The following is a description of a gene set: Any process that results in a change in state or activity of a cell (in terms of movement, secretion, enzyme production, gene expression, etc.) as a result of an ultraviolet radiation (UV light) stimulus. Ultraviolet radiation is electromagnetic radiation with a wavelength in the range of 10 to 380 nanometers. studied in species Homo sapiens Human Gene Set: GOBP_CELLULAR_RESPONSE_TO_UV, and this is the list of marker genes: ERCC1, RBX1, ST20, MDM2, HYAL2 (NCBI Gene Id 8692), SMPD1, PTPRK, COPS9, POLH, MC1R (NCBI Gene Id 4157), TAF1, OPN3, INO80, BAK1, TP53INP1, OPN1SW, EIF2S1, POLD3, RUVBL2, TMEM161A (NCBI Gene Id 54929), MAPK11, CRIP1, PRKCD, OPN5, DDB1, BAX, CERS1, RPL26, KDM1A, EP300, TP53, ERCC4, FBXW7, PBK, PIERCE1, NOC2L, NLRP1, AURKB, XPA, RHBDD1, MAP3K20, POLD1, MME, SIRT1, POLA1, XPC, ACTR5, MMP2, PARP1, MAPK14, POLK, CREBBP, ATF4, N4BP1, USP28, CDKN1A, TRIAP1, MAPK13, RHNO1 (NCBI Gene Id 83695), ZBTB1, HYAL3, HYAL1, MFAP4, AQP1, CUL4B, METTL3, YY1, PCNA, MMP3, PPID, PIK3R1, TREX1 (three prime repair exonuclease 1), SDE2, MMP1, NFATC4 (nuclear factor of activated T cells 4), EI24, DDB2, EIF2AK4, CASP9, ATR, DHX36, NPM1, BMF, NEDD4, CUL4A (cullin 4A), NSMCE3, MMP9, STK11, H2AC25, MYC, TIMP1